Given this list of marker genes CDKN2A, here is a description of the gene set: studied in species Homo sapiens In cell culture, p14ARF (CDKN2A transcript 4, CDKN2A-4, ARF), one of the two main protein products of the CDKN2A gene, contributes to oncogene induced senescence by stabilizing TP53 (p53). The function of p14ARF in p53 stabilization through sequestration of MDM2, a p53 ubiquitin ligase, depends on the nuclear localization of p14ARF and its ability to interact with MDM2. The nuclear localization signal and the MDM2 interaction domain map to the first 15 amino acids of the N-terminus of p14ARF. This region is encoded by the p14ARF-specific exon 1beta of CDKN2A. An independent MDM2-binding domain localized to the C-terminus of p14ARF. Insertion of 16 nucleotides in exon 1beta results in a frameshift truncation of p14ARF, responsible for a familial melanoma syndrome in which the p16INK4A product of the CDKN2A gene is unaffected. This mutation is rare and has so far been reported in one family only. The mutant protein, p14ARF V22Pfs*46 has the nucleotide localization signal and the N-terminal MDM2 interaction region preserved, but is unable to translocate from the cytosol to the nucleus, possibly due to aberrant conformation (Rizos, Puig et al. 2001), and also lacks the C-terminal MDM2 interaction region. Relocation of wild type p14ARF to the cytosol has been observed in melanoma (Rizos, Darmanian et al. 2001) and aggressive thyroid papillary carcinoma. Genomic deletion of exon 1beta, with exons 1alpha, 2 and 3 intact, has been reported in about 30% of melanoma cases with genomic deletions involving the CDKN2A locus. Several different familial melanoma germline mutations map to the exon 1beta splice donor site.<br>The ability of p14ARF to localize to the nucleolus also plays a role in p14ARF-mediated stabilization of p53. Mutations in exon 2 of the CDKN2A gene can lead to missense mutations in p14ARF that affect its nucleolar localization and p53 stabilization, but the exact mechanism has not been fully elucidated. Reactome Pathway: Evasion of Oncogene Induced Senescence Due to p14ARF Defects part of: Diseases of Cellular Senescence